The following is a description of a gene set: studied in species Mus musculus Mouse Gene Set: REACTOME_ESTABLISHMENT_OF_SISTER_CHROMATID_COHESION Establishment of Sister Chromatid Cohesion, and this is the list of marker genes: Pds5b, Pds5a, Smc3, Cdca5, Stag1, Rad21, Esco2, Esco1, Stag2, Wapl, Smc1a (structural maintenance of chromosomes 1A)